Given this list of marker genes PKP1, KDM6A, KMT2D, CD3G, SYK, ELF4, NCF4, TGFB1, MNX1, here is a description of the gene set: An abnormal connection between the epithelialised surface of the anal canal and the perianal skin. Human Gene Set: HP_ANAL_FISTULA Anal fistula studied in species Homo sapiens